Given this list of marker genes ADORA3, P2RY2, P2RY11, ADORA1, ADORA2A, P2RY4, P2RY13, LPAR4, P2RY12, LPAR6 (lysophosphatidic acid receptor 6), P2RY10, ADORA2B (adenosine A2b receptor), GPR17, P2RY14, P2RY1, P2RY6, here is a description of the gene set: Human Gene Set: REACTOME_NUCLEOTIDE_LIKE_PURINERGIC_RECEPTORS Nucleotide-like (purinergic) receptors studied in species Homo sapiens